Given this list of marker genes TARS1, SPIDR, NR5A1, DHH, AARS1, PSMC3IP, DHX37, SRY, VAMP7, TWNK, FSHR, CARS1, RXYLT1, MSH4, BNC1 (basonuclin zinc finger protein 1), BMP15, MPLKIP, NUP107, TOE1, ZSWIM7, PPP1R12A, NR0B1, PPP2R3C, HSD17B4, MRPS22 (NCBI Gene Id 64953), MINPP1, ERCC3, ZFPM2, POLR3H, GTF2H5, SOX9, ERCC2, WT1, WWOX, GATA4, MAP3K1, RNF113A, GTF2E2, here is a description of the gene set: Human Gene Set: HP_GONADAL_DYSGENESIS studied in species Homo sapiens Gonadal dysgenesis is the name given to any of a multitude of conditions that can cause impaired development of the gonads, i.e., the testes or ovaries, or to the related phenotypic features. The term is to be avoided if possible for new annotations, and more specific terms should be chosen. Gonadal dysgenesis